Given this list of marker genes Pdgfra, Pdgfrb, Ptn, Kdr, Nrp1, here is a description of the gene set: Binding to a vascular endothelial growth factor. studied in species Mus musculus Mouse Gene Set: GOMF_VASCULAR_ENDOTHELIAL_GROWTH_FACTOR_BINDING